The following is a description of a gene set: The chemical reactions and pathways involving alkanesulfonates, the anion of alkanesulfonic acids, sulfonic acid derivatives containing an aliphatic hydrocarbon group. species: Mus musculus Mouse Gene Set: GOBP_ALKANESULFONATE_METABOLIC_PROCESS, and this is the list of marker genes: Baat, Phgdh, Stat5b, Fmo1, Cdo1, Pter, Stat5a, Csad, Fmo3, Ghr